Given this list of marker genes NCF2, SLC26A9, TGFB1, CIITA, FOXN1, NTRK1, SLC9A3, RFXANK, ITGB2, SLC11A1, RFXAP, DCTN4, CFTR, GSTM3, RFX5, LYST, SERPINA1, MIF, CEACAM3, CEACAM6, PGM3, GCLC, IRAK4, EDNRA, CLCA4, CYBA, CYBB, HMOX1, SLC6A14, HFE, KCNN4, IL17RA, NCF1, STX1A, FCN3, STAT3, here is a description of the gene set: Increased susceptibility to staphylococcal infections, as manifested by recurrent episodes of staphylococcal infections. Recurrent staphylococcal infections Human Gene Set: HP_RECURRENT_STAPHYLOCOCCAL_INFECTIONS species: Homo sapiens